Given this list of marker genes Cbx8, Sf3b3, Evx1os, Fbxo7, Yeats4, Pias4, Ikbkb, Brd8, Mettl1, Taf5l (NCBI Gene Id 71789), Nek10, Zswim4, Fbh1, Pramel38, Ccnb3, Klhl15, Cdk7, Fbxl7, Atg101, Ercc8, Sf3b5, Taf7l, Pycard (NCBI Gene Id 66824), Ccnt1, Pramel61, Ube2i, Pcgf5, Trex1, Arih2, Klhl21, Prkag1, Naa50, Fbxo27, Jarid2 (jumonji and AT-rich interaction domain containing 2), Riok1, Sptssb, Pole4, Snrpd1, Armc8, Ccnb1, Psmc5, Cdk13, Trmt10c, Klhl38, Fbxl12, Pramel29, Chuk, Ube2d1, Pik3c3, Mtf2, Kbtbd2, Pcgf6, Hoxb5os, Polr1c (polymerase (RNA) I polypeptide C), Pdhx, Vcp, Cdk1, Mib2, Klhl41, Akap14, Las1l, Rnf40, Pole3, Cdc16, Zfp335, Kmt2a, Arih1, Prdm4 (NCBI Gene Id 73308), Cbx7, Kbtbd7, Pramel48, Cks2, Prkar1a, Pcgf3, Ext2, Golga7b, Phka1, Ost4, Smc6, Fem1b, Dcaf11, Sptssa, Atg16l2, Klhl1, Cdc20b, Sptlc1, Tes3-ps, Epc1, Crbn, Pramel14, Trp53rka (transformation related protein 53 regulating kinase A), Fem1c, Trmt11, Pramel44, Msl2, Lztr1, Anapc7, Med17, Magt1, Vac14, Rbx1, Phkg2, Pramel1, Klhl28, N6amt1, Pigt, Insrr, Ccne1, Cbx5, Irs1, Med11, Ccni, Naa10, Ezh2, Anapc2, Myzap, Anapc10 (NCBI Gene Id 68999), Brca2, Commd1, Zyg11a, Znfx1, Bod1l, Polr2j, Rnf19b, Senp3, Polr2m, Oog1, Sesn2, Klhl20, Mocs2 (molybdenum cofactor synthesis 2), Ramac, Rnf8, Ruvbl2, Snrpb, Msl3l2 (MSL3 like 2), Erh, Fbxl17, Gtf2e2, Actb, Ceacam2, Dcun1d3, Polr3k, Rpap1, Stt3b, Pramel43, Traf7, Uvrag, Acvr2a, Klhl18, Trim21, Cxxc1, Qtrt1, Tprkb, Prkacb, Dld, Setd1a, Morf4l1 (mortality factor 4 like 1), Fem1a, Med12, Tbc1d5, Cdc26, Fbxo39, Cdk12, Dpm3, Bod1 (NCBI Gene Id 69556), Pramel50 (NCBI Gene Id 666203), Ccnt2, Ikbkg, Phc2, Anapc16, Polg, Mat2a, Fbxl9, Pik3cb, Ceacam1, Pfkp, Rpn2, Prkci, Taf9b, Dcaf4, Rnf20, Tex10, Ube2a, Atxn7l3, Ccna1, Thumpd2, Pkm, Acvr1b, Fbxo15, Chaer1, Actl6b, Skp2, Pramel6, Nrbf2, Xrcc6, Phf19, Rchy1, Rad18, Ccin, Gtf2h5, Trmt61a, Mat2b (NCBI Gene Id 68881), Cdc23, Phc3, Becn1, Samd7, Gpr37, Polr3e, Zyg11b, Kctd13, Dad1, Cdc27, Asb12, Fbxo45, Rnf2, Asb17, Iscu, Oog4, Ube2n, Fbxo3, Pramel26, Dcaf5, Krtcap2, Abat, Actbl2, Actg1 (NCBI Gene Id 230535), Men1, Fbxo2, Ogt, Erhrt-ps, Pramel53, Ivns1abp, Klhl24, Med23, Dcaf7, Cdk5r1, Nsmce3 (NSE3 homolog, SMC5-SMC6 complex component), Pramel54, Dmac2, Det1, Cbx4, Rnf144b, Uty, Igf1r, Ccna2, Nus1, Ccnh, Klhl8, Dcun1d1, Pramel12, Smurf2, Rbm15, Fbxo42, Ube2s, Elob, Fbxl2, Kat8, Ccnc, Pcgf2, Wdr41, Pdss1, Pik3cg, Ube2v1, Mlec, Polr1b, Zdhhc9, Brpf1, Pggt1b, Fzr1, Gtf2a1, Ubr2, Brcc3, Hdac9, Ramacl, Fbxl14, Dcaf13, Med24, Gnptg, Kat7, Pold4, Pef1, Ccnj, Anapc1, Pik3r4, Pigc, Rnf217, Fbxl22, Xrcc5, Rmnd5a, Pigp, Lyrm4, Usp22, Supt3, Pramel21, Pramel49, Tert, Pigh, Dmap1, Pramel5, Ostc, Prps1, Thg1l, Ruvbl1, Trim37, Fam8a1, Rnmt, Taf1, Fbxo8, Pigm, Taf10, Pramel47, Rev3l, Prkaa1, Polr2e, Klhl30, Prkdc, Polr2c, Cul5, Usp47, Brd8dc, Ube2v2, Ercc3, Appbp2, Klhl29, Polr2i, Pigq, Fbxw8, Snrpe, Naa30, Eloc, Nsmce2, Taf4, Cdk5r2, Polr2f (NCBI Gene Id 69833), Hdac6, Supt7l, Ing3, Med27, Tgfbr2, Polr3g, Anapc15-ps, Yeats2, Jade1, Eny2, Gmppa, Ankrd9, Ube2srt (NCBI Gene Id 620508), Asb2, Ccnd2, Zzz3, Anapc13, Tgfbr1, Nscme3l, Taf11, Pramel25, Kansl3, Maea, Fbxl19, Ercc2, Cab39, Rnf144a, Pramel30, Fbxw5, Prkx, Lrrc75a, Dcaf15, Vhl, Mlst8, Polr3h, Jade2, 9630013A20Rik, Mcrs1, Atg3, Pik3r1, Clns1a, Pagr1a, Traf2 (TNF receptor-associated factor 2), Cdkn2d, Otulin (NCBI Gene Id 97965), Trrap, Kbtbd6, Kctd17, Skic8, Daw1, Spsb2, Anapc5, Cdk4, Prpsap1, Wdr4, Phkb, Prkab1, Klhdc3, Pramel15, Asb4, Taf8, Med18, Prmt1, Pramel17, Pramel31, Insr, Pole, Rabggta, Ormdl3, Fbxo25, Brca1, Epc2, Dr1, Aurkaip1, Naa15, Med20, Prkag2, Taf12, Med10, Ndufab1, Cdk11b, Ddb2, Fbxo24, Cul2, Eid3, Atf2, Ctag2, Trp53rkb, Qtrt2, Pramex1, Supt20, Pramel24, Gm6993, Rictor, Spop, Klhl9, Sgf29, E2f6, Megf8, Setd1b, Fbxo6, Nsmce1, Naa35, Gmppb, Spopl, Cbx2, Polr3gl, Ccny, Rpn1, Topors, Siah1a, Phf20, Tmem258, Ccne2, Plaa, Mbip, Ccnb1-ps, Tuft1, Fbxl21, Polr1a, Stub1, Phf20l1, Fntb, Polrmt, Ccno, Kat6b, Prim1, Taf6l, Fbxo31, Sirt1, Prps1l3, Fbxw4, Kbtbd3 (kelch repeat and BTB (POZ) domain containing 3), Pigu, Papss1, Aebp2, Dapk1, Gnmt, Ing5, Klhl42, Ccnd3, Bcor, Dcaf10, Pold2, Pfkm, Mettl14 (NCBI Gene Id 210529), Mgrn1, Brpf3, Kdm6a, Tbpl1, Wdr77, Pik3r3, Wdr26, Mtor, Mnat1, Klhdc2, Cul4a, Smc5, Fbxw11 (F-box and WD-40 domain protein 11), Ncoa6, Rbbp7, Pklr (NCBI Gene Id 18770), Pramel28 (NCBI Gene Id 626922), Prpsap2, Rnf7, Tada2a, Cbx6, Prkar2a, Sptlc2, Pnkp, Wdr5b, Cdk16, Cop1, Tmem183a, Mga, Rnf31, Suz12, Naa25, Pdcd6, Polr2b, Naa38, Mapkap1, Mkln1, Dph1, Ilvbl, C9orf72, Pparg, Fbxl13, Cdk9, Prps1l1, Tusc3, Klhl40, Gon7, Trpc4ap, Becn2, Pramel55, Bmi1, Gtf2h4, Rbm15b, Btrc, Nsd1, Zswim5, Hcfc1, Alg14, Abtb1, Pelp1, Virma, Ubr3, Elobl, Ccnl2, Klhl22, Gtf2f1, Wdfy3, Fbxl4, Dbf4, Cacybp, Taf6, Snrpert, Prkn, Asb11, Ccnq (cyclin Q), Acvr2b, Morf4l2, Gpaa1, Glmn, Ubac1, Cul9, Ube2j2, Dnmt3l, Zbtb7a, Atg12, Rnf19a, Rnf7l, Pramel56, Klhl23, Sptlc3, Smcr8, Bccip (NCBI Gene Id 66165), Polr2h, Phka2, Polr1h, Pramel22, Prkar2b, Dpy30, Sel1l, Ankib1, Naa16, Keap1, Pik3r6, Ugt3a1, Prkar1b, Pramel11, Kat2a, Leo1, Med21, Ugt3a2, Cnppd1, Pramel35, Taf3, Pcgf1, Dph2, Babam2, Crebbp, Taf7, Pik3cd, Kmt2c, Pramel59, Taf5, Polr2d, Kansl2, Tbp, Ctag2l2, Ccng2, Kctd10, Rmnd5b, Atg13, Phc1, Pramel13, Skp1, Ccnjl, Ring1, Paxip1, Pramel39-ps, Tada2b, Pramel32, Fbxl3, Polr1f (NCBI Gene Id 72166), Dcaf8, Ep300, Hadha, Fbxl6, Pramel45, Acte1, Pdha2, Dhdds, Cul3, Prkaa2, Wdr82, Dydc1, Klhl4, Fbxl16, Ube2d2a, Fbxl5, Rnf11, Csnk2a2, Med6, Phf1, Max, Pcmtd1, Pold3, Nfs1, Dda1, Mat1a, Rbbp4, Rbx1-ps, Cand1, Oog3, Depdc5, Phkg1, Spsb3, Kansl1l, Cdc73, Kdm6b, Pramel42 (PRAME like 42), Syvn1, Pigk, Gm13040, Rad51, Ormdl2, Fbxl18, Zswim6, Socs7, Trim63, Dtl, Rtf1, Atg14, Sharpin, Dcaf12, Hdac2, Prpf31, Kmt2b, Ctu1, Csnk2a1, Trmt6, Rb1, Anapc15, Polr2g, Dcaf8l, Socs2, Dcaf1, Gtf2f2, Taf2, Mrgbp, Pramel19, Dlat, Gtf2h1, Stt3a, Kat14, Ube3d, Med30, Cdk10, Chd8, Fbxw7, Pard6a, Snrpf, Klhl2, Fbxl15, Fnta, Spsb4, Meaf6, Kbtbd12, Ube2e1, Polr3f, Csnk2b, Kat6a, Nsmce4a, Prkab2, Med1, Tada1, Cdk3, Cdk8, Fem1al, Pigv, Anapc4, Polr1e, Wtap, Trmt112, Rabggtb, Tada3, Ypel5, Klhl10, Klhl11, Ezh1, Cks1brt, Prps2 (NCBI Gene Id 68297), Pramel20, Cul1, Ccnb2, Dpm2, Prkaca (protein kinase, cAMP dependent, catalytic, alpha), Pomt1, Naa20, Tcea1, Ube4b, Rnf168, Klhdc10, Snrpd2, Msl3, Prdm8 (NCBI Gene Id 77630), Fbxo17, Acacb, Pfkl, Ing4, Ddost, Pramel60, Pola1, Mad2l2 (NCBI Gene Id 71890), Dcaf6, Fbxl20, Kansl1, Asb9, Pramel27 (PRAME like 27), Paf1, Oog2, Ulk1, Pramel46, Snw1, Polr2a, Hsd17b10, Tex24, Brcc3dc, Ccng1, Cks1b, Pole2, Cdk2, Strada, Ccnf, Hmga1, Hadhb, Golga7, Pik3ca, Pramel37, Enc1, Stradb (NCBI Gene Id 28142), Klhl17, Pramel7, Gid8, Klhl13, Cdkn1a, Chm, Trim40, Dcun1d2, Eed, Ube4a, Dcaf12l2, Map3k7, Kat2b, Epop, Vps72, Prim2, Pold1, Dcaf17, Pramel18, Dyrk2, Gtf2e1, Klhl3, Stk11, Pdhb, Ube2b, Cul7, Cdc20, Elovl6, Pramel23, Med7, Ccnl1, Neurl2, Ep400, Pramel36, Klhl35, Rnf14, Alg13 (NCBI Gene Id 72688), Pcna, Atxn7, Ranbp9, Ranbp2, Ctag2l1, Med13 (NCBI Gene Id 68851), Pramel33, Klhl12, Atg16l1, Naa12, Kmt2d, Amn1, Pramel57 (NCBI Gene Id 100041354), Klhl7, Kbtbd8, Dpm1, Pigs, 0610010K14Rik, Ambra1, Anapc11, Pramel16, Dna2, Wdr5, Zswim8, Kctd2, Klhdc1 (kelch domain containing 1), Hsd17b12, Nccrp1, Polr3d, Fbxo4, Pik3r2, Cdk5, Osgep (O-sialoglycoprotein endopeptidase), Snrpg, Asb1, Ubr1, Gtf2a1l, Chml, Mettl3, Ranbp10, Pramel40, Polr3b, Gtf2h3, Piga, Polr3a, Polr1d, Pex2, Crcp, Katna1, Spsb1, Polg2, Actl6a, Dcun1d4, Ipp, Fbxo44, Kat5, Msl1, Pola2, Pramel41, Erc1, Cdkn1b, Ino80c, Klhl25, Brd4, Taf9, Taf13, Map3k5, Fxn (frataxin), Prmt5, Cdk14, Ctr9, Itch (NCBI Gene Id 77732), Pramel34, Zer1, Brd1, Polr3c, Jade3, Fbxo32 (NCBI Gene Id 67731), Taf4b, Cdk6, Prkag3, Brap, Pfkfb1, Ccnk, Rbck1, Tnfaip1, Zc3h13, Cul4b, Ash2l, Ormdl1 (ORM1-like 1 (S. cerevisiae)), Snrpd3, Hcfc2, Pyurf, Kctd5, Bard1, Naa11, Polr1g, Gtf2b, Rb1cc1, Pigyl, Acvr1c, Rangap1, Samd11, Wdtc1, Mbtd1, Polr2k, Polr2l, Rbbp5, Klhl5, Lage3, Gtf2a2, Klhl6, Ube2c, Dcun1d5 (defective in cullin neddylation 1 domain containing 5), Primpol, Atg5, Pik3r5, Gid4, Fbxo9, Med31, Gtf2h2, Fbxo48, Pramel51 (NCBI Gene Id 100039315), Pdss2, Ddb1, Cbll1, Pard3, Amfr, Nedd4, Dcaf12l1, Acvr1, Ccnd1, Gan, Cblc, here is a description of the gene set: A protein complex capable of catalyzing the transfer of a group, e.g. a methyl group, glycosyl group, acyl group, phosphorus-containing, or other groups, from one compound (generally regarded as the donor) to another compound (generally regarded as the acceptor). species: Mus musculus Mouse Gene Set: GOCC_TRANSFERASE_COMPLEX